The following is a description of a gene set: Human Gene Set: GOBP_NUCLEOBASE_CONTAINING_COMPOUND_TRANSPORT The directed movement of nucleobases, nucleosides, nucleotides and nucleic acids, into, out of or within a cell, or between cells, by means of some agent such as a transporter or pore. studied in species Homo sapiens, and this is the list of marker genes: CKAP5, TST, NXF2, POM121B, NDC1, ZC3H11B, G3BP2, SLC25A23, MVP, FXR2, SLC25A42 (NCBI Gene Id 57831), ALKBH5, NRDE2, ANKH, NUP214, ARC, RANBP2 (NCBI Gene Id 5903), NUP42, ABCD2, CALHM3, LRRC8D, PHAX, ABCC11, NXF2B, EIF4A3, SLC35D2, ADCY10, CALHM1, SLC28A1, NCBP3, THOC7, SLC17A9, SLC28A3, NUP62, PCID2, SLC25A5, AGFG1, CHTOP, POM121C, SMG7, RBM15B (NCBI Gene Id 29890), IWS1, SLC25A52, NOL6, NUP88, LRRC8B, UPF3A, PEG10, NCBP1, IGF2BP1, SLC35A5, KIF5C, HNRNPA2B1 (heterogeneous nuclear ribonucleoprotein A2/B1), SLC35B1, DHX9, FMR1, SEC13, SEM1, SLC25A33, SLC46A2, SARNP, THOC2, SLC29A1, DDX19B, EPG5, RFTN2, SLC25A41, RAN, C12orf50, SLC35A1, THOC6, ZC3H11C, QKI, UPF3B, SMG6, SUPT6H, ZFP36L1, SLC29A4, SLC25A6, MAGOHB (mago homolog B, exon junction complex subunit), NUP153, MAGOH, SLC25A47, SLC25A16, SLC19A1, SRSF7, NUP210, SLC35C1, XPO5, CD47 (NCBI Gene Id 961), POM121L2, THOC5, FYTTD1, RBM33, SLC35B2, BICD2, NUP50, DDX39B, SETD2, YBX1, SLC35C2, SLC29A2, HNRNPA1, NUP54, SLBP, ALYREF, NXF5, RBM8A, SLC35D3, NCBP2, WNK1, AKAP8L, ZC3H11A, NXF1, TPR, ZC3H3, RANBP17, NXT2, RSC1A1, KHSRP, LRRC8E, SLC25A4, TMEM241, NUP85, SLC35B4, IGF2BP2, TOMM20, SENP2 (SUMO specific peptidase 2), THOC1, RAE1, AAAS, LRPPRC, NUP93, NUP98, HSF1, SLC35D1, POM121, ABCD1, NUP188, RBFOX1, PANX1, EIF4E, DDX25 (DEAD-box helicase 25), CETN2, SLC33A1, SMG1 (SMG1 nonsense mediated mRNA decay associated PI3K related kinase), NUP133, SLC35A2, SLC35A4, PARP11, LRRC8A, SLC25A17, DDX39A, DDX19A (DEAD-box helicase 19A), CASC3, SNUPN, ENY2, NPAP1, CALHM4, SLC35E3, SLC28A2, PNPT1, ABCC1, TOMM20L, MCM3AP, NUP205, MX2, RTRAF, KHDRBS1, SIDT2, MRPL18, FLOT1, POLDIP3, NUP160, NUP58, CPSF6, SLC25A25 (solute carrier family 25 member 25), SLC25A36, ABCC4, XPOT, SIDT1, KPNB1, NXF3, AHCTF1, SLC25A19 (NCBI Gene Id 60386), TNKS, CALHM6, SLC35A3, ABCC5, CR1, NUP155, SMG5, YTHDC1, SSB, FXR1, SLC25A24, RFTN1, PABPN1, LRRC8C, NUP35, SLC25A53, ABCC6, THOC3, HNRNPA1L2, IGF2BP3, NUP43, NXT1, NPIPA1, NUP107, SLC29A3, TGFBR2, LUZP4, UPF1, SLC25A26, CALHM5, NSUN2, CALHM2, SLC25A31, ADORA1, CETN3, SRSF1, P2RX7, NUTF2, SRSF3, SLC35B3, UPF2, HHEX, NUP37, XPO1, NEAT1, GLE1, SLC25A32, SLC25A51, ATXN2, SEH1L, ZFP36, SHOC2